Given this list of marker genes NINJ1, ITGAL, MECOM, HBE1, BLNK, PTPN13, MST1R, RORA, HTR3A, KIF3B, FLI1, IL17RA, CEBPA (NCBI Gene Id 1050), MAP2K7, SRPK1, MAP6, RUNX1, MKNK1, TFRC, MADCAM1, CCNE1, here is a description of the gene set: species: Mus musculus from publication Numata A, Shimoda K, Kamezaki K, Haro T, Kakumitsu H, Shide K, Kato K, Miyamoto T, Yamashita Y, Oshima Y, Nakajima H, Iwama A, Aoki K, Takase K, Gondo H, Mano H, Harada M (PMID 15664994) Target genes for STAT3 in CSF3 signaling during myeloblast differentiation to neutrophils. Human Gene Set: NUMATA_CSF3_SIGNALING_VIA_STAT3 The Janus kinase (Jak)-Stat pathway plays an essential role in cytokine signaling. Granulocyte colony-stimulating factor (G-CSF) promotes granulopoiesis and granulocytic differentiation, and Stat3 is the principle Stat protein activated by G-CSF. Upon treatment with G-CSF, the interleukin-3-dependent cell line 32D clone 3(32Dcl3) differentiates into neutrophils, and 32Dcl3 cells expressing dominant-negative Stat3 (32Dcl3/DNStat3) proliferate in G-CSF without differentiation. Gene expression profile and quantitative PCR analysis of G-CSF-stimulated cell lines revealed that the expression of C/EBPalpha was up-regulated by the activation of Stat3. In addition, activated Stat3 bound to CCAAT/enhancer-binding protein (C/EBP)alpha, leading to the enhancement of the transcription activity of C/EBPalpha. Conditional expression of C/EBPalpha in 32Dcl3/DNStat3 cells after G-CSF stimulation abolishes the G-CSF-dependent cell proliferation and induces granulocytic differentiation. Although granulocyte-specific genes, such as the G-CSF receptor, lysozyme M, and neutrophil gelatinase-associated lipocalin precursor (NGAL) are regulated by Stat3, only NGAL was induced by the restoration of C/EBPalpha after stimulation with G-CSF in 32Dcl3/DNStat3 cells. These results show that one of the major roles of Stat3 in the G-CSF signaling pathway is to augment the function of C/EBPalpha, which is essential for myeloid differentiation. Additionally, cooperation of C/EBPalpha with other Stat3-activated proteins are required for the induction of some G-CSF responsive genes including lysozyme M and the G-CSF receptor.